Given this list of marker genes ABCG5, KMT2D, HNRNPK, CARS1, XYLT1, SCN2A, IFIH1, HEXA, FLNA, RNASEH2B, RPS10, RPS7, SPTBN1, MFAP5, YY1, PTH1R, CRELD1, ERCC8, DNAH9, SDHD (NCBI Gene Id 91899), TKT, B3GAT3, ATP2B1, CEP57, ABCG8, PRPF3, ZSWIM6, UBA1, AGXT, TBX5, RPL31, DISP1, BRCC3, NEDD4L, MLXIPL, IPO8, RRAS2, PPP2R1A, COL5A2, PTEN, CDH2, BGN, LAMB2, CHD4, PDGFRB, TMEM127, PLOD3, BAZ1B, RAI1, PPFIBP1, MAP3K7, FUCA1, LRP6, FZD4, UBE3B, TALDO1, TULP1, AMER1, ATN1, ADK, EFEMP1, FANCM, BRF1, CLXN, ADA2, LARS2, PRKCSH, RNU7-1, MT-ND1, COL1A2, RFWD3, APC2 (NCBI Gene Id 10297), MAP2K1, TPM2, ZEB2, FLI1, BRAF, RAD51C, SLC20A2, CSF2RB, DOHH, NADSYN1, MT-ND6, BICC1, COL1A1, PUF60, NKX2-6, LRPPRC, LPL, GALC, CAT, FANCF, GDF1, SCAF4, CREBBP, MYH7, PCNT, STAT1, PGM1, PTCH1 (patched 1), FANCL, LRP5 (NCBI Gene Id 8058), DDX6, ALG3, LZTR1, FLT4, GUCY1A1, FANCB, EP300, SEC63, ZNF148, HOXA1, SLC25A22, GJA8, RPS17, SOS2, RNU4ATAC, P4HA2, MID1, MAD2L2, MAX, NOD2, TBX1, VAC14, PALB2, DLK1, BCOR, HEATR3, STRA6, NFIA, DGCR6, PKD1L1, SPEN, PNPLA2, GJA1, FANCE, HLA-B, SEMA3E, DLL1, MEG3, NXN, UFD1 (NCBI Gene Id 7353), DNMT3A, DNAH1, NDE1, APOA5, ALG5, OSGEP, COL3A1, DIS3L2, NSMCE2, ATP6V1E1 (NCBI Gene Id 529), NF1, KCNQ2, JAG1, PKD1 (NCBI Gene Id 5310), MYPN, RNASEH2A, RIN2, TSR2 (NCBI Gene Id 90121), TAF4, MMP23B, ERCC4, PTPN11, LOX, SMAD3, NDUFB11, ANAPC7, MYLK, CBL, TSC2, ESS2, CASZ1, GAS1, SUCLG1, LDLRAP1, RPS26, NCF1, RPS27, DDX3X, CYP7A1, TNXB (NCBI Gene Id 7148), THSD4, DYRK1B, KDM5A, TBC1D24, CFAP53, C12orf57, FANCC, LIMK1, THBS2, RPL27, APOB, PRDM16, ZMYM3, ESAM, ERCC6, RPS19, SLC2A10, RPL26, SMAD4, ZIC3, HTRA1, GATA6, LMX1B, PAH (phenylalanine hydroxylase), ARVCF, PKD2, BUD23, ANGPTL6, CDON, MMP14, METTL27, ALG9, TBX20, NOTCH3, IFNG, PIK3CD, PLCB1, RPS29, TMEM260, TGIF1, TGFBR3, TBL2, PSAP, WAC, HGD, NEK1, NEU1, IFT56, ARF1, CELA2A, DNAJB11, PLXND1, ENPP1, TGDS, CSF2RA, VPS37D, GJA5, ZMPSTE24, TRAF7, FMR1, ADAMTS19, MAPK1, FKBP14 (NCBI Gene Id 55033), GTF2IRD2, RPS24, EFEMP2, ERMARD, APOE, NIPA1, BUB1B, NPR3, CRKL, SRCAP, TELO2, AEBP1, RPL5, ENG, FOXH1, HEXB, PRKAR1A, NAA60, PDPN, TUBG1, FANCD2, GTF2I, PPP1R17, APP, GHR, LTBP1, TAB2, CHRNG, RPL18, PLOD1, CTSA, PDGFB, MYOC, BRIP1 (BRCA1 interacting helicase 1), CPLANE1, GATA1, STX1A, NRAS, APOA2, NPC1, SF3B2, PRKCZ, ROR2 (receptor tyrosine kinase like orphan receptor 2), FOXF1, CRIPTO, MYH3, ERCC3, GEMIN4 (NCBI Gene Id 50628), FKBP6, IDS, ABCA1, NOTCH1, LIPC, HEY2 (NCBI Gene Id 30830), FOXE3, CTCF, GABRD, ALDH18A1, MLX, SMARCAL1, MEF2A, SCN1A, DHCR7, ROBO4, CHD7, COX7B, TNNT2, ERCC5, GLB1, GM2A, STAG2, TBCK, RNASEH2C, HSPG2, MT-CYB, PIK3CG, SMAD6, RPS20, MKS1, HBB, ABCD4, NKAP, SKI, MT-ND5, FBN2, NDP, RNF213, TGFBR1, WDR26, ASAH1, PTPN22, MED12, MYRF, THPO, POLR1A, SAMHD1, AFF4, DPH5, WRN, MYH11, RPL35, SPECC1L, TGFBR2, ATP7A, LSM11, RFC2, RERE, GNB2, RREB1, ADAMTSL1, JMJD1C, BCR, FBXO11, GP1BB, B3GALT6, UBE4B, RAD51, EPHX2 (NCBI Gene Id 2053), FLNB, FGFR1, CYP1B1, BEST1, GATA4, DNAJC30, ZIC2, XYLT2, GANAB, FANCA, PIGA, ARFGEF2, FANCG, PPP1CB, MMP2, ALMS1, GTF2IRD1, ALDH1A2, MCTP2, SC5D, RPL9, RIT1, GLI3, MEIS2, MT-ND4, LMNA, CIROP, CYP27A1, ABCC6, GLI2, NIPA2 (NCBI Gene Id 96367), FARSB, TRRAP, EMILIN1, FIG4, GAA, KCNH1, SLC12A5, ESR1, SHH, COMT, HCCS, COL4A1, RNU4-2, RPL11, RAP1B, VHL, GATA5, EIF4H, GNA11 (NCBI Gene Id 93626), RET, ANTXR1, PGM3, GBA1, MYCN, SON, HRAS, GPIHBP1, PCSK9, EHMT1, NKX2-5, TONSL, SMARCA2, BANF1, NAE1, ACVR2B, SMG9, GGCX, THSD1, APOA1, SIX3, ABL1, F12, RPL8, BRCA1, TREX1, BUB1, KNSTRN, BUB3, SLC34A2, HES7, STIL, RAF1, CLIP2, KANSL1, MT-ND2, UNC45B, KCNAB2, RTL1, KRAS, FANCI, CHST3, DYNC2LI1, FBN1, RPL35A, NEK9, BMPR2, ATP6V1A, RRAS, JAK2, NT5E (NCBI Gene Id 4907), NR2F2, SLX4, FBLN5, PCGF2, PIGN, ZNF687, IL12B, SPRED2, TPM3, HDAC4, MMP21, YME1L1, PDE11A, SMPD1, LDLR, MT-ND4L, RBM8A, NODAL, MRAS (NCBI Gene Id 654181), SLC25A24, IFT140, CDK8, KDM6A, MAT2A, LIPA, ADAR, CEP19, SELENOI, YY1AP1, POU3F4, DARS1, NSD1, SOS1, MAP1B, TMEM67, RPGRIP1, SRY, RPS15A, SERPIND1, RASA2, TMEM270, HIRA, ACTA2, DGCR2, IGFBP7, XRCC2, ANO1, MT-ATP6, PIK3R2, RPL15, KCNT1, SMAD2, ERCC2, ARL6IP6, FGF8, WT1, ELN (NCBI Gene Id 2006), LYN, TGFB2, PLD1, MT-CO3, TRIP13, TSC1 (NCBI Gene Id 7248), NPC2, BRCA2, LCAT, LUZP1, TMTC3, HLA-DRB1, SEC24C, SUPT16H, TGFB3, FGFR2, EGFR, HYOU1 (hypoxia up-regulated 1), UBE2T, PPARG, DCDC2, PRKG1, MPL, COL5A1, DGCR8, RPS28, WDPCP, ZFX, here is a description of the gene set: studied in species Homo sapiens An abnormality of the systemic arterial tree, which consists of the aorta and other systemic arteries. Human Gene Set: HP_ABNORMAL_SYSTEMIC_ARTERIAL_MORPHOLOGY Abnormal systemic arterial morphology